Given this list of marker genes DLG3, CNTN2, NRP2, ANK1, NRCAM, DLG1, DLG4, here is a description of the gene set: The NgCAM-related cell adhesion molecule (NrCAM) is member of the L1 family involved in the eye development and node of Ranvier. Like all the other members of L1 family NrCAM also has the ability to bind to ankyrins. The last C-terminal amino acids of NrCAM form a PDZ-binding motif and can interact with SAP (synapse-associated protein) 102 and SAP97. Member of the GPI-anchored TAG-1/axonin-1 have been shown to interact with NrCAM. NrCAM also binds the Sema3B receptor NP-2 to mediate repulsive axon guidance. part of: L1CAM interactions Reactome Pathway: NrCAM interactions studied in species Homo sapiens